The following is a description of a gene set: from publication Fu W, Ergun A, Lu T, Hill JA, Haxhinasto S, Fassett MS, Gazit R, Adoro S, Glimcher L, Chan S, Kastner P, Rossi D, Collins JJ, Mathis D, Benoist C (PMID 22961053) Human Gene Set: GSE40274_LEF1_VS_FOXP3_AND_LEF1_TRANSDUCED_ACTIVATED_CD4_TCELL_DN Genes down-regulated in CD4 T conv over-expressing LEF1 versus LEF1 and FOX3P. studied in species Homo sapiens The transcription factor FoxP3 partakes dominantly in the specification and function of FoxP3+ CD4+ T regulatory cells (Tregs), but is neither strictly necessary nor sufficient to determine the characteristic Treg transcriptional signature. Computational network inference and experimental testing assessed the contribution of several other transcription factors (TFs). Enforced expression of Helios or Xbp1 elicited specific signatures, but Eos, Irf4, Satb1, Lef1 and Gata1 elicited exactly the same outcome, synergizing with FoxP3 to activate most of the Treg signature, including key TFs, and enhancing FoxP3 occupancy at its genomic targets. Conversely, the Treg signature was robust to inactivation of any single cofactor. A redundant genetic switch thus locks-in the Treg phenotype, a model which accounts for several aspects of Treg physiology, differentiation and stability., and this is the list of marker genes: LPIN1, ZC3H8, TTC7B, ETV3, NRROS, RPH3AL, SLC32A1, HOXB6, RGMB, UBE2QL1, MPHOSPH9, DNAH8, PIP4K2A, FOCAD, ABLIM1, DOP1A, ALS2CL, DENND11, NACC2, CNGA1, HERC3, IL21, RAB3D, LEF1, MGAT4A, SATB1, PRKACB, THEMIS, DSE, SRPK1, AMZ1, MFHAS1, NUFIP1, ZKSCAN8P1, PACS2, CXCL11, TTYH3, MOB3B, TP53I13, IL17RA, CBFB, C8orf58, ITGB3, ATP8B4, MSN, RCC1L, ARMC6, GPN1, SGK1, WWTR1, ARV1, SPRR3, SNRPD3, KLHDC1, METTL21A, SMURF2, SIAH1, SLC7A1, PRAM1, OXCT1, ADD3, PIM2, TOM1, EYA2, EMB, LIPT1, TMEM9B, PPIC, CATSPER3, PABIR1, UTP25, PARP11, ACTR6, UBXN11, ZNF318, MAML2, PLEKHG6, CD40LG, THAP6, ARHGEF18, ICAM2, IRAG1, FBXO17, DIMT1, F2R, GALNT6, NUDT12, P4HA2, DPH5, CDC20B, NMNAT3, BCL9, KLHL25, PPP1R36, EEIG1, CAMK1D, IGF2BP2, METTL25, HID1, GGT5, GFOD2, MFSD6, PUS7L, ITK, DUSP10, XKRX, TMEM63A, HECTD2, ZNF438, ORAI2, SETD4, QTRT1, FNTB, TEX44, ANAPC11, PPP2R5A, ISL1, TBC1D16, RASGRP2, IBTK, ST8SIA1, ABCG2, RNF122, ADGRG3 (NCBI Gene Id 58870), DDX18, NFE2L2, EVL, PCED1B, POLR1G, RAB11FIP4, B4GALT7, TMIE, SLC49A4, SLC25A44, ID2, LRATD2, IFIT2, ABRAXAS2, STK38, USP12, HS3ST3B1, GMFG, TRAT1 (NCBI Gene Id 51488), IMPDH1, FGF11 (NCBI Gene Id 2256), APP, GRAMD2B, ERO1B, ARHGAP39, SMARCA2 (NCBI Gene Id 95083), FAT3, DYRK2, DZIP1, RDH13, DAAM1, FASLG, GOLT1B, TMEM71, MEOX1, SLC16A5, NUDT6, EXD1, ZBTB16, COMMD8 (NCBI Gene Id 54951), PDK1, TSPYL4, THNSL1, COX10, TRIO, ACVR1B, CIMIP1, RIGI, DIAPH2, HSDL1, STARD7, PWP2, MBP, ARHGEF9, PDE7A, TDRP, WNT5B, PRF1, GEMIN5, STX17, NUMB, SMG9, FOLR1, STK17B, ABHD15, ADGRG5, PLEKHO1 (pleckstrin homology domain containing O1), ABTB3, ZPR1, ZNF770, GPR183, ACAT1, EHD3, CXCR6, TSPAN5